Given this list of marker genes BDNF, RPL3L, NOTCH1, CCN3, HDAC3, HDAC5, CEACAM5, HDAC1, XBP1, MIR200B, TRIM72, MYOCD, HDAC4, NKX2-5, BHLHE41, BHLHA15, TMEM119, PLPP7, here is a description of the gene set: Human Gene Set: GOBP_NEGATIVE_REGULATION_OF_MYOTUBE_DIFFERENTIATION Any process that decreases the frequency, rate or extent of myotube differentiation. Myotube differentiation is the process in which a relatively unspecialized cell acquires specialized features of a myotube cell. Myotubes are multinucleated cells that are formed when proliferating myoblasts exit the cell cycle, differentiate and fuse. studied in species Homo sapiens